The following is a description of a gene set: Any process that stops, prevents, or reduces the frequency, rate or extent of heterochromatin formation. Mouse Gene Set: GOBP_NEGATIVE_REGULATION_OF_HETEROCHROMATIN_FORMATION species: Mus musculus, and this is the list of marker genes: Kmt2a, Phf8, Dnmt3l, Phf2, Dyrk1a, Rlf